Given this list of marker genes PTK2B, ABCA1, PKN2, MAP2K5, NOS3, CITED2, SRC, SMAD6 (NCBI Gene Id 4091), HAS2, ABL1, MIR92A1, PRKACG, PTGS2, MMP2, TGFB1, MIR126, MAPK7, AKT1, P2RX4, SREBF2, GNAS, ASS1, PRKACB, PLEC, CAPN2, PRKACA (protein kinase cAMP-activated catalytic subunit alpha), MTOR, KLF2, SMAD7, PPP2CA, P2RX7, KLF4, PTPN1, CSF2, HDAC3, PKD2, MEF2C, PKD1, PDPK1, NFE2L2, SOCS5, MTSS1, PTK2, XBP1, here is a description of the gene set: Any process that results in a change in state or activity of a cell or an organism (in terms of movement, secretion, enzyme production, gene expression, etc.) as a result of a fluid shear stress stimulus. Fluid shear stress is the force acting on an object in a system where the fluid is moving across a solid surface. studied in species Homo sapiens Human Gene Set: GOBP_RESPONSE_TO_FLUID_SHEAR_STRESS